The following is a description of a gene set: Human Gene Set: MIR1207_5P studied in species Homo sapiens Genes predicted to be targets of miRBase v22 microRNA hsa-miR-1207-5p in miRDB v6.0 with MirTarget v4 prediction scores > 80 (high confidence targets). from publication Chen Y, Wang X (PMID 31504780), and this is the list of marker genes: ZFYVE27, PPP1R1B, MNT, POU2F2, BRPF3, CRTC1, SLC7A8, SLC7A1, LDLRAD2, CASTOR2, PPP3R1, PTPN9, CRAT, PLXNA1, RBBP5, CSRP1 (NCBI Gene Id 1465), WNT6, NGEF, TAF12, VANGL2, PCBP3, ABCG4, SLC43A2, KCNE1, CHPF, AGAP1, UBE2M, CDK5R1, CCND3, SARM1, ATG16L1, RAP1GAP, MAPK8IP1, GTPBP2, ATRN, CPEB2, DCHS1, GOLGB1, DPP8, PDPK1, CDC42BPB, PEF1, SEPTIN9, ZNF740, ITM2C, MECP2, USP4, SSH2, MTCL2, MTA3, SLC22A8 (NCBI Gene Id 9376), WNT7B, ZNF285, CD276, NR6A1, SDK2, RCVRN, STAT6, ABHD4, SLC22A11, AKAP5, GNAO1, DAGLA, STAG1, AFAP1L1, CHRM1, DDX3X, SLC6A17, WDTC1, TP53I11, UBE2Z, OPA3, DUSP13A, MAFG, ANGEL1 (NCBI Gene Id 23357), SLC13A5, TPTE, SIX5, FAM120C, CLASP1, IPO9, OTOF, FXYD5, GNA14, CACNA2D1, NDRG1, NFIC, RHOJ, NOS1, ATG9A (autophagy related 9A), SSR3, MEF2C, CFAP77, SH3KBP1, NAT8L, RXRA, CCDC102A, PPP1R1A, RAB43, KCNG1, ETV6, NPTXR, VASP, SMARCD1, ETF1, FOSB, CACNB3, NHERF2, FA2H, FOXJ3 (forkhead box J3), RASL10B, TOB2, JAKMIP3 (Janus kinase and microtubule interacting protein 3), NATD1, ARC, LFNG (LFNG O-fucosylpeptide 3-beta-N-acetylglucosaminyltransferase), CBX2, PLEC, SLC45A4, AXIN1, APOL6, CEMIP, HK1, TNK2, BCL7B, MEDAG, SPR, ESRRG, ZMYM3, PML, PIRT (NCBI Gene Id 649488), SH3PXD2B, HBEGF, EXOC7, TFE3, NOVA1, ATP11A, KIF21B, PRR15L, INSM1 (INSM transcriptional repressor 1), IL6ST, DRD2, RAP1GAP2, TUBB6, TRMT61A, CNIH2, MLST8, TMA7, F7, PBX1, RARA, VAMP1, ACVRL1, ADAMTS10, SLC6A9, CCL22, GID4, ABCC5, CLDN19, ISM2 (isthmin 2), GATAD2B, PHB1, TTC5, FUNDC2, ELFN2 (extracellular leucine rich repeat and fibronectin type III domain containing 2), CST9, NBPF1, ZFP41, SCN2B (NCBI Gene Id 6327), FOXM1, SDC1, MYEOV, LYST, MAPK8IP3, CORO2B, RAB1B, NBPF3, BCAN, TLN1, GIT2, STK40, CDH10, FOXN2, CAV1, ASXL1, VPS11, KIAA0513, TEAD3, NPY4R2, SLC35E4, CHAD, NAA60, ZHX3, GALNT2, MAP1B, B4GALNT1, SLC25A23, NACC1, SFXN5, EPHA10, SF3A1, UNK, PAK3, MAGT1, ZMIZ1, B3GNT7, DOLPP1, KDM4B, MPP2, SLC35E2B, BAHD1, SRC, NFASC, ALS2CL, PACS2, SLC35C2, NECTIN1, CAPN7, OBSL1, RLN3, TCAF2, DCUN1D3, CD151, GUCA2A, MLLT6, DUXA, KSR2, C5orf63, CACFD1, TMEM201, STIM1, PITPNM2, ISL2, DNMT3A, THEM5, MON1B, TIFAB, SUSD6, CNTN2, UNC5A, CDR2L, SMYD5, SLC25A14, JADE2, CBX6, CIT, GTDC1, CNNM4, MARK2, SPNS2, SDC3, LSM12, PGM5, NPY4R, ANKRD63, DISP2, MLXIP, TSPAN5, DMBX1, SEMA3F, GNAI2, CCDC170, MRGPRF, PLPPR2, NAV3, CHRNA6, RNF216, CELF5, GPSM1, GRM4, MRAP2, TUBB4A, MAPKAPK2, VAT1, DUSP15, FSTL4, G6PD, TMEM198, SV2A, NALF2, NPTX1, CABLES1, C2orf72, NIPSNAP1, CDH1, LRRC15, HOXA11, BARHL2, MAFK, ORAI2, FBXO41, NSMF, CHD5, ATXN7L3, CTXN1, CYP26B1, ARRB1, LHPP, CHAC1, ZDHHC8, CASC3, PIK3CG, TMCC1, DEF8, KLF6, SLC9A8, CBX5, TMEM229B, HYAL2, ADGRA2, NES, GPR137, POLR1G, LRP1, KRTAP4-5, LINGO1, LRP4, KRT80, LENG8, SLC39A1, NCKAP1, TSPAN9, WBP1L, TRIM67, ATP9B (NCBI Gene Id 374868), SHB, MPZ, UNC13D, PDGFRB, PPTC7, ERF